Given this list of marker genes Ccl8, Ccl19-ps6, Klk5, Ccl25, Ccl7, F2, Pgc, Lgals3, Gapdhrt, Defa39, Ccl27a, Nod2, Camp, Rps19, S100a9, Ppl, Leap2, Elane, Ccl21e, Reg3g, Defa25, Ang6, Ccl19-ps4, Ang, Ivl, Pomc, Pf4, Bpifa1, Ccl19-ps1, Ang2, Xcl1, Fam3a, Defa38, Defa17, Cxcl10, Ccl19, Cxcl11, Defa21, AY761185, Ccl21d, Defa23, Ccl27b, Ccl4, Dmbt1, App, Cxcl9, Hmgn2-ps, Reg3a, Defa37, Bpi, Reg2, Gapdhrt2, Cxcl13, Cxcl15, Fau, Rpl39, Ccl27al, Hamp2, Adm, Defa35 (defensin, alpha, 35), Gapdh, Krt6a, Gapdh-ps15, Ang5 (NCBI Gene Id 503844), Ccl5, Defa2, Reg1, Cx3cl1, Defb21, Defa41, Hrg, Tac1, Romo1, Defb1, Pla2g1b, Ccl19-ps3, Defa3, Ccl3, Ppbp, Spag11b, Defa20, Vip, Ccl17, Npy, Ccl9, Defa31, Ltf, Lgals4 (lectin, galactose binding, soluble 4), Ccl1, Ccl6, Ccl20 (C-C motif chemokine ligand 20), Cxcl5, Cxcl12, Ccl2, Nppb, Ccl12, Hamp, Mmp7, Tslp (NCBI Gene Id 53603), Gm5849, Evpl, Ccl22, Kng2, Defb37, Il17f, Rnase6, Defa42 (defensin, alpha, 42), Ccl21f, Pglyrp4, Defa5, H2bc12, Pglyrp1, H2bc21, Nts, Il17a, Cxcl14, Reg3b, Defa29, Hmgn2, Reg3d, Ccl11, Defa24, Pglyrp3, Ccl21b, Ccl24, Defa22, Defa40, Ccl19-ps5, Ccl26, Rpl30, Galp, Defa28, Ccl21a, Ang4 (angiogenin, ribonuclease A family, member 4), Defb22, Defa30, Defa34, B2m, Klk7, Ccl28, Kng1 (NCBI Gene Id 16644), Bpifa5, Defa26, here is a description of the gene set: species: Mus musculus An immune response against microbes mediated by anti-microbial peptides in body fluid. Mouse Gene Set: GOBP_ANTIMICROBIAL_HUMORAL_IMMUNE_RESPONSE_MEDIATED_BY_ANTIMICROBIAL_PEPTIDE